The following is a description of a gene set: from publication Chaussabel D, Semnani RT, McDowell MA, Sacks D, Sher A, Nutman TB (PMID 12663451) Human Gene Set: GSE360_CTRL_VS_L_MAJOR_MAC_UP Genes up-regulated in comparison of macrophages versus macrophages exposed to L. major. Monocyte-derived dendritic cells (DC) and macrophages (MΦ) generated in vitro from the same individual blood donors were exposed to five different pathogens, and gene expression profiles were assessed by microarray analysis. Responses to Mycobacterium tuberculosis and to phylogenetically distinct protozoan (Leishmania major, L. donovani, Toxoplasma gondii) and helminth (Brugia malayi) parasites were examined, each of which produces chronic infections in humans yet vary considerably in the nature of the immune responses they trigger. species: Homo sapiens, and this is the list of marker genes: ARHGAP1, NARS1, ABL1, RBCK1, SLC4A7, NDUFAB1, GMFG, RIN2, PART1, MISP, SPN, SMARCC1, USP10, NKX2-8, POM121, CT62, SET, FCGRT, VPS39, ANAPC5, LDHB, PHYH, SRSF1 (NCBI Gene Id 650453), PRDX2, RBM8A, ASMTL, NBL1 (NBL1, DAN family BMP antagonist), PFDN6, GLIPR1, IRF5, TTC39A, APLP1, MAK16, SNRPE, PTPN18, SPRR1A, SFTPB, MAGEA4, PEBP1, GALK2, TCAP, PDS5B, IGF2, PRKACB, UBE4B, PCMT1, DHCR7, NDUFV1 (NCBI Gene Id 4723), RNASE6, STX12, APOBEC3C, ITGB2, GANAB, DHX16, DNAH7, BRINP1, SNAPC5, SLC25A44, RFC2, APEX2, RGS14, NFATC3 (nuclear factor of activated T cells 3), SMAD3, GLG1, CTNNB1, EPS15, KLHL9, TLE2, NECAB3, CYP7A1, NAA80, ATP6V0D1, TUBB2A, LAMTOR5, AHNAK, EZH1, ACVR1B, SLC43A1, ZNF629, ALG3, VAMP1, DPYSL2, MARCO (NCBI Gene Id 8685), CEBPA, UROD, BRD3 (NCBI Gene Id 9763), RPL27, ZBTB25, CRAT, ADGRG6, EIF2B5, CYC1, FBXW11, SYK (NCBI Gene Id 6850), PEMT, OVOL2, EXTL3, GPSM3, ERCC5, GTF2H5, IMPDH2, PMPCB, MYOZ2, P2RX5, SMARCA4, SH3GL1, CKAP5, SREBF2, LRPPRC, SERPINH1 (NCBI Gene Id 89588), CHRND, BANF1, ENO1, DDX52, MARS1, IRAK3, ABCA2, ZSWIM8, GFUS, RAP1GDS1, MAPRE3, HLA-E, RPE, NR2C1, FAM13A, DDB2, BTN3A2, PFDN5, ABCB7, ADIPOR2, MED8, RPRD2, FRG1, CDC25B, MSH2, SPOP, ARHGEF16, SLC36A1, CPVL, SMARCE1, CALCOCO1, LSM4, MTOR, CHAF1A, RPL4, KEL, PUF60, CDK3, RPH3A, PSKH1, KAT5, DCP2, DGAT1, PCCA, NDUFA2, MSMB, CAPN11, TBC1D2B, NDUFS4, ACTA2 (NCBI Gene Id 59), SMARCC2, TRAPPC12, HAGH, VPS26C, RPS6KA1, CD163, FOS, MYH10, DNAH17, CFD, GDI2, OTUB1 (OTU deubiquitinase, ubiquitin aldehyde binding 1), PSMA7, MARCHF2, PRCP, RAC3, PPBPP2, SLC4A3, INPP5D (inositol polyphosphate-5-phosphatase D), RNASE1 (NCBI Gene Id 6035), NDUFS7, ARHGEF1, TMEM94, RAE1, SUMO1, MEA1, ESR1, POLR3C, HDAC1, PLCG2, WNT4 (NCBI Gene Id 54361), EIF4G2, NREP, NUP133, POP5 (POP5 homolog, ribonuclease P/MRP subunit), ATP5PD, ARHGAP45, TTC1, PLRG1, PRRC2B